Given this list of marker genes ILDR1, GRIPAP1, CACNG7, HEPACAM, ZDHHC2, DAG1, JAM3, ASIC2, ZDHHC15, BAIAP2, MAPT, JAK1, GRIP2, KIF5A, GHSR, ACTB, KIF3A, ARHGAP44, VAMP4, PECAM1, CDK5, ERBB4, FLNA, SCRIB, WNT5A, GRIP1, HSPB1, F11R, RELN, RAB27B, DVL1, HRAS, KIF2C, NPTX1, NLGN1, CACNG2, STAU2, DSG2, RAB11A, MAPK8IP3, C1QL2, ZDHHC7, ZDHHC12, STX3, PCLO, NECTIN3, MPP4, NSG1 (NCBI Gene Id 27065), STAU1, OGT, VCL, LSR, RAPSN, NRXN1 (neurexin 1), CGNL1, TMEM108, CNIH3, DLG3, VWC2, ERBB2 (erb-b2 receptor tyrosine kinase 2), NPHS1 (NPHS1 adhesion molecule, nephrin), DLG2, SLITRK3, RAP1A, NECTIN1, OLFM1, GABARAP, CPLX1, MAP2K1, IQSEC2, TJP3, DLG1, ADAM10, DSG3, KIF5C, VPS35, WNT7A, HEG1, BSN, CACNG3, TJP1, TJP2, LAMTOR3 (NCBI Gene Id 8649), VPS26B, DLG4, GRIN2C, SACM1L, CTNND1, NRXN2, GPHN, MARVELD3, NETO2, LHFPL4, NETO1, TRAF6, MAP1A, ACTG1, DLG5, DSP, CLSTN3 (calsyntenin 3), SHANK1, LRRC7, MPP7 (NCBI Gene Id 143098), FERMT2, CACNA2D2, ABCB1, GIT1, GPSM2, C1QL3, MAPK9, LAMTOR2, KIF5B, LGI1, NLGN2, EPB41L3, CLSTN1, GPC6, GPC4, GRIN2A (NCBI Gene Id 2903), RAB8A, ABHD17B, LRRTM1, ARHGEF18, CDH5, PAK2, here is a description of the gene set: Human Gene Set: GOBP_PROTEIN_LOCALIZATION_TO_CELL_JUNCTION A process in which a protein is transported to, or maintained in, a location within a cell junction. species: Homo sapiens